Given this list of marker genes SRSF6, CELF3, PRMT5, PCBP4, RBM23 (NCBI Gene Id 95712), ARB2A, RBM10, PUF60, RBMY1F, RBMY1E, RBMY1A1, JMJD6, DDX5, EXOSC10, RBPMS, CWC22, KHDRBS1, THRAP3, NPM1, RBM25, MYOD1, SRSF7, RBM20, SRPK2, SRRM4, RBM11, RBM15B, KHDRBS2, UPF3B, DYRK1A, SRPK1, RBM42, RBMY1J, SRSF10, PRDX6, RBM3, TRA2B, FMR1 (fragile X messenger ribonucleoprotein 1), NOVA1, SLC39A5 (solute carrier family 39 member 5), RBM4, RNPS1, NOVA2, TRA2A, WDR77, SRSF3, UPF1, RBM5, UPF3A (NCBI Gene Id 95832), SNRNP70, DAZAP1, ARGLU1, RBFOX3, CELF5 (NCBI Gene Id 60680), SMU1, RBM24, SRSF4, SRSF12, HNRNPU, NCL, RBMX, THUMPD2, SRSF8, RBM47, RBMXL1, RBM8A, NSRP1, RBFOX1, ACIN1, KHDRBS3, YTHDC1, CLNS1A, C1QBP, LARP7, RBM39, RBMY1D, SRRM1 (serine and arginine repetitive matrix 1), HNRNPA1, STH, DDX17, SRSF9, CIRBP, TIA1, PRPF19, RBM7 (NCBI Gene Id 51120), NCBP1, RBMY1B, SRSF2, NUP98, REST (RE1 silencing transcription factor), METTL16, CELF6, CELF2, SAP18, MAGOH, ZBTB7A, QKI, HNRNPL, PTBP1, SNW1, RBPMS2, RBFOX2, HNRNPK, HMX2, WTAP, RBM15, U2AF2, SON, CELF1, CELF4, SF1, SFSWAP, here is a description of the gene set: Any process that modulates the frequency, rate or extent of mRNA splicing via a spliceosomal mechanism. studied in species Homo sapiens Human Gene Set: GOBP_REGULATION_OF_MRNA_SPLICING_VIA_SPLICEOSOME